The following is a description of a gene set: studied in species Mus musculus Mouse Gene Set: GOBP_PROTEIN_METHYLATION The addition of a methyl group to a protein amino acid. A methyl group is derived from methane by the removal of a hydrogen atom., and this is the list of marker genes: Eef1akmt2, Ehmt2, Kmt5a, Gm15222, Mettl21a, Ilf3, Fam98b, Ntmt1, Mettl18, Ntmt2, Setd6, Wdr5, Carm1, Eef2kmt, Prdm1, Atpsckmt, Ehmt1, Eef1akmt1, Setd3, Setd2, Smyd2, Ndufaf7, Snrpb, Snrpd3 (NCBI Gene Id 78379), Btg1, Rab3b, Antkmt, Icmt, Lcmt1, Mettl22, Etfbkmt, Lcmt2, Mettl21c, Prmt8, Camkmt, Kmt2a, Prmt7, Rab6a, Pcmt1, Etf1, Prmt5, Vcpkmt, Eef1akmt3, N6amt1, Gspt1, Rab3d, Btg2, Fam98a, Prdm12 (PR domain containing 12), Comt, Prmt1, Trmt112, Setd7